Given this list of marker genes BCL2L1, MCAM, DGKQ, HGD, DUSP1, H1-2, GAK, CTNND1, GGT7, MYO9B, DNAH17, SLC25A16, MBD4, ENKD1, RBMS2, RMC1, ZFP36L2, GNPTG, PPP1R12C, TUSC2, FBH1, ARHGEF10 (NCBI Gene Id 9639), NCOA1, CHMP4B (charged multivesicular body protein 4B, NCBI Gene Id 60501), TGM2, UBR4, AFTPH, ACAP3, ODF2, CYP1B1, GLI3 (NCBI Gene Id 2737), ESAM, CHI3L1, PDPK1, ADSS2, SBNO1, GALT, DLX4, NOS3, ADGRB2, RINT1, CYB5B, CNKSR1, FNBP4, DSE, MIR22HG, SYNJ1, SMARCD3, CDKN1C, CALCOCO1 (NCBI Gene Id 57658), ID2, RETSAT, PRKCD, CORO7, NAALADL1, ABCD3, ID3, ISG15, AAMDC, SLC2A2, CCN2 (cellular communication network factor 2), here is a description of the gene set: from publication Mariadason JM, Corner GA, Augenlicht LH (PMID 10969808) Cluster 9: genes up-regulated in SW260 cells (colon cancer) by sodium butyrate and TSA with the same kinetics with which each alters the level of histone H4 acetylation. The short-chain fatty acid butyrate, produced by microbial fermentation of dietary fiber in the large intestine, is a physiological regulator of major pathways of colonic epithelial cell maturation: cell cycle arrest, lineage-specific differentiation, and apoptosis. Microarray analysis of 8,063 sequences demonstrated a complex cascade of reprogramming of SW620 colonic epithelial cells upon treatment with butyrate characterized by the progressive recruitment of gene sets as a function of time. Comparison with the effects of trichostatin A, in conjunction with differences in the kinetics of alteration of histone acetylation induced by butyrate and trichostatin A, identified subsets of induced and repressed genes likely coordinately regulated by altered histone acetylation. The butyrate response was also compared in detail with that of sulindac, a nonsteroidal anti-inflammatory drug with significant chemopreventive activity for colon cancer, and curcumin, a component of mustard and curry structurally and functionally related to sulindac that also has chemopreventive activity. Although gene clusters were identified that showed similar responses to butyrate and sulindac, the data were characterized by the extensive differences in the effects of the two agents. This was striking for functional classes of genes involved in signaling pathways and in cell cycle progression, although butyrate and sulindac induce a similar G0-G1 arrest, elevation of beta-catenin-Tcf signaling, and apoptotic cascade. As regards cell cycle arrest, the underlying mechanism in response to butyrate was most similar to that of the Caco-2 cell line that had spontaneously undergone a G0-G1 arrest and least similar to the G2-M arrest stimulated by curcumin. Thus, high-throughput microarray analysis of gene expression profiles can be used to characterize and distinguish the mechanisms of response of colonic epithelial cells to physiological and pharmacological inducers of cell maturation. This has important implications for characterization of chemopreventive agents and recognition of potential toxicity and synergies. The data bases, gene clusters, and analyses are available at http:// sequence.aecom.yu.edu/genome/. studied in species Homo sapiens Human Gene Set: MARIADASON_REGULATED_BY_HISTONE_ACETYLATION_UP